The following is a description of a gene set: Genes up-regulated in comparison of PTPRC- CD4 T cells versus activated regulatory T cell (Treg). species: Homo sapiens from publication Miyara M, Yoshioka Y, Kitoh A, Shima T, Wing K, Niwa A, Parizot C, Taflin C, Heike T, Valeyre D, Mathian A, Nakahata T, Yamaguchi T, Nomura T, Ono M, Amoura Z, Gorochov G, Sakaguchi S (PMID 19464196) Gene expression profiles of subsets of CD4+ T cells according to their expression of FoxP3 and CD45RA were compared. FoxP3 is a key transcription factor for the development and function of natural CD4+ regulatory T cells (Tregs). Here we show that human FoxP3+CD4+ T cells are composed of three phenotypically and functionally distinct subpopulations: CD45RA+FoxP3low resting Tregs (rTregs) and CD45RA-FoxP3high activated Tregs (aTregs), both of which are suppressive in vitro, and cytokine-secreting CD45RA-FoxP3low non-suppressive T cells. The proportion of the three subpopulations characteristically altered in cord blood, aged individuals, and patients with immunological diseases. Terminally differentiated aTregs rapidly die while rTregs proliferate and convert into aTregs in vitro and in vivo as shown by the transfer of rTregs into NOD-scid-common gamma-chain-knockout mice and by TCR sequence-based T cell clonotype tracing in peripheral blood of normal individuals. Taken together, the dissection of FoxP3+ cells into subsets enables one to analyze Treg differentiation dynamics and interactions in normal and disease states, and to control immune responses through manipulating particular FoxP3+ subpopulations. Human Gene Set: GSE15659_CD45RA_NEG_CD4_TCELL_VS_ACTIVATED_TREG_UP, and this is the list of marker genes: BBOX1, CD40LG, KLHL30-AS1, CD7, CCS, DYNC1I1, SCN8A, FKRP, ZGRF1, B3GAT1, CD46, ASMTL-AS1, EIF2AK3, EFNB1 (NCBI Gene Id 1947), CCDC33, CDH19, NELFB, CPNE3, CHRNB2, EIF2AK2 (eukaryotic translation initiation factor 2 alpha kinase 2), DNASE1L2, SPMIP10, CABP2, ASB15, ALKBH7 (alkB homolog 7), AFAP1, ARHGAP29, AGK, MYRF-AS1, AVPR1A, LINC03040, ALX4, C4orf36, GCAT, ZNF736, DAD1, LINC00951, CCDC152, MFSD12, ADCY9, CYP2E1, GJB3, TLCD3B, ENTPD3, ZBTB7C-AS2, CCDC97, LINC02880, CSTA, DPYS, ANKMY1 (ankyrin repeat and MYND domain containing 1), SMG8, COL6A6, GPAT4, SCP2D1, C10orf53, PXYLP1, CSNK1D, ABHD1, CCNY, C2orf15, PAGR1, LINC01588, CUBN, BTAF1, ENTPD2, DACT1, CXCL14, DHX58, BPI, CST3, DNAH17 (dynein axonemal heavy chain 17), ARL4A, CFAP298, FAM219B, CDHR5, GIMAP8, EVX1, CDC26, GGA2, CFAP47, CASKIN2, CITED4, ARHGAP5, DLX1, EEF1D, FUS, ARHGEF19, FOS, NR2F1-AS1, ANGPT4, CBY3, BAZ1A, PRR29, BEND4, CYMP, COL10A1, CDK5RAP2, FAAP100, INTS6L, ARSJ, FGF23, DLL3, ANKRD45, ACOT6, TMBIM1, GABARAPL3, TBC1D32, ADAMTSL3, ARHGAP35, BAALC-AS2, CLU, ACTR3B, CES1, CECR2, DUS1L, C1QTNF7, ASCL3, DMTN, EFCAB10, COIL, LY6S-AS1, ART4, CHRNA2, DGCR5, ADH7, BLCAP, LINC01550, CPLX2, DDA1, ATP13A5, FLYWCH2, CYFIP1, CHPF, CLTCL1, TMEM263, CDS1, FBXL16, CNPY1, FSIP1, FBXW9, CRBN, EXOC2, GFPT2, CEP68, RHNO1, ERLEC1, MVB12B, CACNA1A, GFRA1, CALCA, ETV6, CC2D1B, RMDN3, OGFOD3 (NCBI Gene Id 79701), ALPK1, ARPIN, AVEN, CABLES1, ADAMDEC1, FPGS, CHD9, FHL1, ALDH1L2, FST, FNDC8, TBATA (NCBI Gene Id 219793), BAHD1, GEMIN4, CREB3L4, CXCL16, ATXN3L, FAM47A, ATOH7, MUCL3 (NCBI Gene Id 53370), CYSLTR2, CYP4Z1, CEACAM19, FAIM, BOLA1, FXYD5, AGRN, ARIH1, SOWAHA, AEBP2, GABRR3, ASF1A, ENPP3, SUCO, BDNF, CMTM5, CAMK1D, C1orf210, NOCT, CHRNA4, CXXC1P1, TEX38, CACNG7